The following is a description of a gene set: species: Homo sapiens Human Gene Set: HP_FETAL_DISTRESS Fetal distress An intrauterine state characterized by suboptimal values in the fetal heart rate, oxygenation of fetal blood, or other parameters indicative of compromise of the fetus. Signs of fetal distress include repetitive variable decelerations, fetal tachycardia or bradycardia, late decelerations, or low biophysical profile., and this is the list of marker genes: SPEN, NDUFAF8, CTCF, ALDH7A1, TMEM126B, NDUFB3, GOSR2, SLC6A9, NDUFV1, CAMK2B, NDUFAF3 (NADH:ubiquinone oxidoreductase complex assembly factor 3), IL1RN, PEX2, NDUFV2, NDUFAF4, LRPPRC, MT-ND1, DNMT3A, IKZF1, IFT56 (intraflagellar transport 56), NDUFA10, EXTL3, ATAD3A, COX11 (cytochrome c oxidase copper chaperone COX11), NDUFS1, USP18, ABCC6, RPL11, NDUFS2, MT-ND2, NDUFA11, OSTM1, NDUFA1, SON, MT-ND3, NDUFS7, NDUFS4, IPO8 (importin 8), ATP8B1, NDUFS3, ABCB4, NDUFAF5, NDUFB9, NDUFAF1, NDUFA6, NDUFAF2, NDUFB10, EMC10 (NCBI Gene Id 284361), BUB1, PLPBP, AFF2, LMNA, EXOSC9, PIGA, NDUFS6, ABCD4, SLC2A1, AP1S2, NUBPL, NDUFB11, KCNQ5, NDUFS8, FOXRED1, TIMMDC1 (NCBI Gene Id 51300), ENPP1